Given this list of marker genes MIR26A1 (microRNA 26a-1), ATAD5, ZNF830, MTBP, EIF4G1, PKP3, PKIA, CDC6, CTDSP1, CDK6, SMARCE1, SPC25 (NCBI Gene Id 57405), AKT1, ATR, INCENP, RAD51C, TGFB1, RHNO1, APPL2, SLFN11, DTX3L, VPS4B, MIR520H, DDX3X, CDC14B, TAF1, RRM2B, CDC25B, PLK3, CDK4, FBXW7, BIRC5, MIR137, EZH2 (enhancer of zeste 2 polycomb repressive complex 2 subunit), MOS, LYN, MIR19B1, ERCC6, DOT1L, PBX1, KCNA5, CDC25C, SUSD2, TPRA1, NBN, ATF2, CDKN1A, BRD4, PTPN6, CCNQ, WEE1, CCND1, RIOK2, TREX1, ATRIP, ARID2, CDKN2A, CACNB4, PBRM1, BTN2A2, PAGR1, STK38, PABIR1, NABP1, HUS1, NABP2, USP28, TIPRL, PSME1, TOPBP1, PPP2CA, PRAP1, ACTL6A, APBB2, PPP1R9B, BABAM1, TAOK3, SMARCB1, CDK10, SMARCD2, PKMYT1 (NCBI Gene Id 9088), GPNMB, RBL1, ZC3H12D, CDC14A (NCBI Gene Id 8556), SDE2, SETMAR, USP44, RASSF1, RPA2, TFDP1, CDK7, EME1, RAD21, CLOCK, NOP53, CTDSPL, KIF14, IK, TEX14, BLM, DPF2, AURKA, MAD2L1, GPR15LG, RINT1, RAD1 (NCBI Gene Id 5810), ECD, PHOX2B, TPR, BUB3, HASPIN, TMEM14B, CDK2, STIL, TMSB4X, DDRGK1 (DDRGK domain containing 1), PSME3, BRCA1, SASS6, SMARCC1, SMARCA4, DYNC1LI1 (NCBI Gene Id 51143), CUL4B, MBLAC1, MUS81, RFPL1, ANLN, MNAT1, MBTPS2, RAD9B, ERCC2, PROX1, MIR520A, CDKN1B, PSMG2, FBXO31, PKD2, SKA3, PAF1, STK33, MACROH2A1, MIR195 (microRNA 195), WNT10B (NCBI Gene Id 82499), MIR29A, BCL2, USP50, AMBRA1 (autophagy and beclin 1 regulator 1), NANOGP8, USP17L2, STOX1, TTK, TP53 (NCBI Gene Id 7157), MIR515-1, MIR16-1, APC (NCBI Gene Id 324), CYP1A1, KLF4, FBXO7, PINX1, RRM1, DBF4, ANAPC5, UIMC1, BRIP1, BRSK1, RAD50, TM4SF5, MIR372, XPC, CDC73, NUF2, SPDL1, KLHL22, FBXO5, FBXO4, MDC1, VPS4A, ZFP36L2, WAC, CDK5, CDK3, ANKRD17 (ankyrin repeat domain 17), HINFP, MIR133A1, CDKN2C, STXBP4, RCC2, BRD7, ACTL6B, UBD, AURKB, INHBA, CDC45, MYO16, PKD1, BRCC3, TIPIN, MRE11, INO80, PLK1, XRCC3, MIR15B, DNA2, BID, FAM83D, CHFR, KMT2E, ADAMTS1, MIR222, ZNF16, RRM2, PLK5, TRIAP1, CDCA8 (NCBI Gene Id 55143), MIR208A, CCNE1, ERCC3 (ERCC excision repair 3, TFIIH core complex helicase subunit), MIR873 (NCBI Gene Id 100126316), TTI1, RPTOR, MAP3K20, TFDP3, MIR193A, MIR638, MARK3, ARID1B, BCL7B, E2F7, MIR221, ETAA1, MEPCE, BCL7A, RAD17, SPC24, CDK1 (NCBI Gene Id 983), SENP2, FZR1, MIR892B, DLG1, CDC14C, OVOL1, DPF3, CDC20, DUSP1, CDC7, CCAR2, SMARCD3, RFWD3, DTL, ANAPC4, PLCG2, TIMELESS, TCF3, GIGYF2, CENPF, ACVR1, NPM1, PTENP1-AS, CRLF3, TAOK1, NAE1, HSPA2, CDK5RAP2, KNL1, CDK2AP2, GPR132, TP63, TCIM, NEK6, LSM11, MDM2, DACT1, FAM107A (NCBI Gene Id 50803), MSH2, BCL7C, RGCC, CCNE2, CENPE, RAB11A, PRKDC, MTA3, PRPF19, BUB1B, SIN3A, DYRK3, CCND3, DDB1 (NCBI Gene Id 1642), DBF4B, CDT1, CHMP4C, MRNIP, ARID1A, IER3, GNB1L, CTC1, CDC23, NEK11, ATP2B4, RAD9A, KLF11, HUS1B, TRIM39, FBXO6, BABAM2, ING4, ATM, CCNB1, CCL2, CDK14, SMARCA2, MBTPS1, ABRAXAS1, MIR362, PLCB1 (phospholipase C beta 1), DDR2, TBX2, E2F1, MN1, ANAPC15, INTS3, UFL1, AVEN, PRP4K, MAD1L1, MIR503, PDIK1L, RBL2, RNASEH2B, BUB1, MIIP, KCNH5, CLSPN, CENPJ, DCUN1D3, FHL1, PSME2, MIR133B, CPSF3, RAD51, CEP63, RPA4, HORMAD1 (HORMA domain containing 1), SIRT2, GTPBP4, PAXIP1, CHEK1, APPL1 (adaptor protein, phosphotyrosine interacting with PH domain and leucine zipper 1), CRY1, CCNH, ESPL1, INIP, TTI2, CTDSP2, KLHL18, ZWINT, TELO2, TFAP4, ZNF207, GEN1, DPF1, ZWILCH, CDC5L, CDKN2B, AIF1, PTPN11, CAMSAP3, LSM10, KANK2, NSMCE2, TAOK2, ACTB, CDKN1C, KNTC1, CUL3, PARP9, RAD51B, PPP1R10, SIX3, MIR15A, FGF10, ID2, WDR76, DGKZ, MIR451A, SMARCD1, FEM1B, NEUROG1, APBB1, ZFP36L1, CDC16, BRCA2, ZNF655, ANAPC7, GLI1, TMOD3, MIR30C2, HEXIM2, NPM2, PTEN (phosphatase and tensin homolog), MUC1, DONSON, MIR214, MIR10A, CDK18, FOXN3, SOX2, MAD2L1BP, NDC80, GFI1B, TICRR, MIR519D, HECW2, NEK10, CDC25A, PHF10, MLF1, CHEK2, ADAM17, TRIP13, ZFYVE19, SKA1, CDKN2D (NCBI Gene Id 1032), FANCD2, NSUN2, UBE2E2, CUL4A, STK35, LCMT1, ORC1, SMARCC2, MIR29B1, BARD1, ANAPC11, EIF2AK4, EME2, ANXA1, MAPK15, ZW10, H2AX, ATF5, DLGAP5, MAD2L2, RB1, CRNN, MIR29C (microRNA 29c), UBE2C, CCND2, FOXO4, RDX, TERT, CDK17, MAPK14, EGFR, CDK5RAP3, CDK15, PLRG1, TP53BP1, CDK16, CDCA5, RBBP8, RPS27L, SYF2, JADE1, INTS7, PRMT2, MIR495, here is a description of the gene set: Any process that modulates the frequency, rate or extent of cell cycle phase transition. studied in species Homo sapiens Human Gene Set: GOBP_REGULATION_OF_CELL_CYCLE_PHASE_TRANSITION